The following is a description of a gene set: Genes predicted to be targets of miRBase v22 microRNA mmu_miR_12188_5p in miRDB v6.0 with MirTarget v4 prediction scores > 80 (high confidence targets). Mouse Gene Set: MIR_12188_5P from publication Chen Y, Wang X (PMID 31504780) species: Mus musculus, and this is the list of marker genes: Vat1l, Kctd14, Rfx3, Syt1, Prom1 (NCBI Gene Id 19126), Cyb561a3, Ccny, Phlpp2, Stimate, Usp17la, Stum, Fads1, Cyp4a12a, Kprp, Sec22c, Frmpd3, Cept1, Epc1, Psd3, Cdr2l, Cstpp1, Kcnq3, Rsbn1, Sox11, Fitm2, Lims1, Cdk19, Grpel1, Nrxn2, Vps26b, Rapgef2, Cldnd1, Slc30a9, Pnn, D5Ertd579e, Fgf12, Dusp10, Bcor (NCBI Gene Id 76075), Gask1b, Siglecl2, Rlig1, Cacng6, Tnfsf12, Map9, Ift81, Trappc2b, Ptprk, Psat1, Adgrl4, Pabir2, Fbxo39, Zbtb37 (zinc finger and BTB domain containing 37), Dapk1, Zfp58, Piezo2, Gpr174 (G protein-coupled receptor 174), Kcnma1, Tram2, Gpr155, Tmem154, Dsg3, Ptprb, Rgcc, Mgat2, Kdelr1, Mgme1, Zfp384, Dgkk, Trappc3, Rd3, Sbk3, Marchf2, Dnajc3, Rtl4, Dnah9, Prr16, Snu13, Slc4a8, Sult1d1, Mpp4, Usp37, Sptbn2, Ptafr, Cct3, Kpna1, Eea1, Phf21a, Kel, Med18 (mediator complex subunit 18), Ccsap, Cybc1, Stard4, Carmil1, Dtd1, Neb, Agtr2, Golga7, Cds1, Vopp1, Rc3h2, Pomk, Slk, Aff4, Tfdp2, Lcorl, Pip4k2c, Gtf3c4, Cyp4a12b, Gpc6 (glypican 6), Klhl31, Zfp870, Or2t48, Gcnt2, Pcdh10, Pcdh17, Ugt2a3, Tfap2a, Kcnb1, Snap23, Ppp2r5c, Zfp735, Neurod1, Dcx, Slfn14, Cdhr1, Vps50, Trim67, Traf3, Phlpp1 (PH domain and leucine rich repeat protein phosphatase 1), Mmp1a (NCBI Gene Id 83995), Rasgrf1, Or10h5, Mecp2, Atxn1l, Pcdh15 (protocadherin 15), Tbr1, Dnajc14, Kcnj6, Dennd4a, Il22ra1, Pdk4, Fgf9, Ceacam20, Srpra (signal recognition particle receptor alpha), Nr2e1, Smim5, Mettl25b, Ipmk, Tc2n, H2-Aa, Specc1, Scfd2, Grhl3, Msx2, Nanos2, Abcg8, Fam98a, Man1a, Otub1, Slamf6, Trib2, Uggt1, Fbxl7, Atp2c1, Mylk4, Rad54l2, Unc5c, Hacd3, Cbl, E2f8, Ehmt1, Ppp1r1c, Pbx1, Ednrb, CK137956, Cyb561, Hnrnpr, Rin2, Cpne8, Sos1, Mrpl27, Epha5, Acp2, Mcm4, Cav1, Tmem47, R3hdm2, Nup155, Cdh7, Dnajc16, Kdm5a, Nfat5, Efhc1, Gjc3, Apln, Foxn2, Timp3, Tram1, Rbm4b, Cracd, Slc6a11, Cadm2, Bdh2, Ube2ql1